The following is a description of a gene set: studied in species Homo sapiens Polyarticular arthropathy Human Gene Set: HP_POLYARTICULAR_ARTHROPATHY, and this is the list of marker genes: KIAA0319L, PTPN22, TREX1, TNFAIP3 (NCBI Gene Id 7128), PDCD1, MECP2, P4HA2, IL10, UBE2L3, NFKBIL1, CCN6 (cellular communication network factor 6), PRG4, TNIP1, DOCK11, CTLA4, IGHG1, STAT3, SLC22A4, TNFRSF1A, CIITA, FCGR3B, PIK3CD, BLK, SPP1, CR2, PXK, DNASE1, ITGAM, C4A, IRAK1, IL36RN, C4B, JAZF1, HLA-DPB1, NLRP1, TLR7, IRF5, NLRP3, HLA-DPA1, ETS1, HLA-DRB1, TNFSF4, ENPP1, BANK1, DMP1, STAT4, NOD2, PRTN3 (NCBI Gene Id 5657), MEFV, CD244, HLA-B, FCGR2B